Given this list of marker genes PRKACA, GPD2, FABP12, CAV1, FABP2, PLIN1, PRKACB, FABP6, GK3, FABP5, FABP4, DGAT1 (NCBI Gene Id 8694), GK2, FABP7, MOGAT1, AGMO, DGAT2, PPP1CA, MOGAT2, LIPE, PPP1CC, GPAT2, FABP3, PLIN3, MOGAT3, ABHD5 (abhydrolase domain containing 5, lysophosphatidic acid acyltransferase), LPIN3, PPP1CB, FABP1, GK, PRKACG, GPAM (NCBI Gene Id 57678), MGLL, FABP9, PNPLA5, LPIN2, LPIN1, PNPLA4, here is a description of the gene set: studied in species Homo sapiens Human Gene Set: REACTOME_TRIGLYCERIDE_METABOLISM Triglyceride metabolism